The following is a description of a gene set: from publication Weinberger B, Haks MC, de Paus RA, Ottenhoff THM, Bauer T, Grubeck-Loebenstein B (PMID 29868000) Human Gene Set: WEINBERGER_BLOOD_TWINRIX_AGE_20_40_AND_60_84YO_CORRELATED_WITH_ANTI_HBS_CONC_PRIMARY_VACC_1DY_SIGNIFICANT Genes significantly correlated with anti-HBs concentration in blood in young/old adults (20-40)/(60-84) (primary vaccination) after exposure to Twinrix, time point 1D. Comment: transcripts that were differentially regulated between individuals with anti-HBs concentrations of >= 10,000 and < 10,000 IU/l studied in species Homo sapiens Many current vaccines are less immunogenic and less effective in elderly compared to younger adults due to age-related changes of the immune system. Most vaccines utilized in the elderly contain antigens, which the target population has had previous contact with due to previous vaccination or infection. Therefore, most studies investigating vaccine-induced immune responses in the elderly do not analyze responses to neo-antigens but rather booster responses. However, age-related differences in the immune response could differentially affect primary versus recall responses. We therefore investigated the impact of age on primary and recall antibody responses following hepatitis B vaccination in young and older adults. Focused gene expression profiling was performed before and 1 day after the vaccination in order to identify gene signatures predicting antibody responses. Young (20-40 years; <i>n</i> = 24) and elderly ( > 60 years; <i>n</i> = 17) healthy volunteers received either a primary series (no prior vaccination) or a single booster shot (documented primary vaccination more than 10 years ago). Antibody titers were determined at days 0, 7, and 28, as well as 6 months after the vaccination. After primary vaccination, antibody responses were lower and delayed in the elderly compared to young adults. Non-responders after the three-dose primary series were only observed in the elderly group. Maximum antibody concentrations after booster vaccination were similar in both age groups. Focused gene expression profiling identified 29 transcripts that correlated with age at baseline and clustered in a network centered around type I interferons and pro-inflammatory cytokines. In addition, smaller 8- and 6-gene signatures were identified at baseline that associated with vaccine responsiveness during primary and booster vaccination, respectively. When evaluating the kinetic changes in gene expression profiles before and after primary vaccination, a 33-gene signature, dominated by IFN-signaling, pro-inflammatory cytokines, inflammasome components, and immune cell subset markers, was uncovered that was associated with vaccine responsiveness. By contrast, no such transcripts were identified during booster vaccination. Our results document that primary differs from booster vaccination in old age, in regard to antibody responses as well as at the level of gene signatures. Clinical: www.clinicaltrialsregister.eu, this trial was registered at the EU Clinical Trial Register (EU-CTR) with the EUDRACT-Nr. 2013-002589-38., and this is the list of marker genes: CCL19, IL7R, CISH, TNIP1, NLRP1 (NLR family pyrin domain containing 1), NLRP12, CD19, TLR3, MARCO, BPI, RAB33A (RAB33A, member RAS oncogene family), GZMA, STAT1, NLRP2, IFI6, IL2, IL9, IL6, CD14, TNFRSF1A (TNF receptor superfamily member 1A), GATA3, IFI44L (interferon induced protein 44 like), IFI35, TLR9, TNF, CD3E, TGFB1, SLAMF7, TNFRSF1B, IFIT5 (NCBI Gene Id 24138), IL22RA1, CXCL9, NLRP4